The following is a description of a gene set: The process pertaining to the initial formation of a limb bud from unspecified parts. This process begins with the formation of a local condensation of mesenchyme cells within the prospective limb field, and ends when a limb bud is recognizable. studied in species Homo sapiens Human Gene Set: GOBP_LIMB_BUD_FORMATION, and this is the list of marker genes: COL2A1, SHH (sonic hedgehog signaling molecule), WNT3, FGFR2, ZNF219 (NCBI Gene Id 54166), SEMA3C, PLXNA2, FGF10, SOX9